Given this list of marker genes SHH, PTEN, RPS6KA3, RAB33B, BICRA, XYLT1, PGAP2, RPS27, NALCN, EIF2AK3, CSGALNACT1, LAMB3, CTSC, RPL27, DYNC2LI1, CWC27, TMEM231, NONO, SKI, TMEM216, GP1BB, CHST11, TGFB2, ADA2, CEP290, JAG1, COL6A3, CTSK, PORCN, KCNN3, MACROH2A1, SALL1, B9D2, ACTG1, DHCR7, TBX3, C2CD3, PROP1, EXTL3, PLOD3, ARID1B, IFT52, SHMT2, OTUD6B, SUZ12, DYNC2H1, COL5A1, INTU, KCNK9, ASAH1, MIR17HG, FGFR3, MIR140, EDA, COL11A2, DNA2, ZNF668 (NCBI Gene Id 79759), ADAMTS15, FTSJ1, FANCC, TNNI2, GABRD, NIN, PTDSS1, TMEM138 (transmembrane protein 138), PIBF1, DEAF1, CHD7 (chromodomain helicase DNA binding protein 7), ZIC3, NUP88, LMBR1 (NCBI Gene Id 85501), TCTN1, UBAP2L, RBPJ, LAGE3, SMOC1, PQBP1, GATA1, SLC29A3, EVC, COL6A2, DOCK6, GPC4, MEIS2, GNAS, PIK3CA, ERCC6, TMEM107, KATNIP, PRKCZ, KMT2A, COL10A1, SMARCA2, MUSK, FLII, WNK1, FGFRL1, RPL8, BMPR1B, IFT122, IDS, BRF1, MAN2C1, CFAP418, COG4, RPS24, MYBPC1, KIF15, RLIM, SPEN, RPS28, MYH8, FANCE, PIEZO2, LONP1, SMARCB1, AKT3, RTL1, ATP6V1B2, MBD5, RMRP, NOD2, SOST, TRPS1, ACTB (NCBI Gene Id 60), TSR2, TGFBR2, GJA5, NSUN2, LIG4, WFS1, MTOR, SMC1A, GDF5, BMPR1A, HPGD, FGF10, PHF8, ARPC4, DYNLT2B, FANCA, LMNA, RPL11, ANAPC1, NOG, ERCC8, MBTPS2, FBXO11, TMEM218, PUF60, IFIH1, LHX4, PAX3, MORC2, ROR2, PRKACA, NLRP3, RPL31, AMMECR1, WDR4, HIRA, FRAS1, H3-3B, ARID1A, FLI1, PHF6, SMO (NCBI Gene Id 6608), EBP, DDX59, RAB23, COMT, MAP3K7 (mitogen-activated protein kinase kinase kinase 7), KIAA0825, DHX30 (NCBI Gene Id 22907), MEGF8, SCLT1, NGLY1, IGHMBP2, EXOSC2, CEP120, DLL4, TCTN3, ACAN, IPO8, RUNX2 (RUNX family transcription factor 2), TAF6, CD96, CANT1, GNPNAT1, EVC2, HSPG2, PRDM16, TOGARAM1, LHX3, RAB3GAP2, TDO2, FAM149B1, FLNA, IFT57, RPL10, TPRKB, BRD4, TRIP11, B4GALT7 (beta-1,4-galactosyltransferase 7), EZH2, TRPV4, MTX2, CEP19 (NCBI Gene Id 84984), CDKL5, WDR35, IGF2, HOXA13, BBS12, RPL35A, TNNT3, RPGRIP1L, CC2D2A, HOXD13, POR, POC1A, TRAPPC2, CDC6, NFKBIL1, TGFB3, NEPRO, ROBO1, ACTG2, PDGFRB, TFAP2A, PIGS, JMJD1C, CNOT1, NELFA, WDPCP, WNT7A, FANCI, CEP41 (centrosomal protein 41), FLNB, UNC80, TMEM70, ARVCF, PEX1, IDH1, ADAMTS3, POGZ, BBS7, SRCAP, RIGI, BCOR (BCL6 corepressor), H3-3A, SMAD3, PIK3CD, PTHLH, ZDHHC9, RREB1, DVL1, GLI2, OCRL, ERCC2, BMP4, KIF1A, COG5, FGFR1, ORC1, PIGG, MMP2, STAMBP, RAB34, CBY1, PIGN, MGP, CEP104, NEK1, MAP3K20, PIGV, GATAD2B, USP9X, CIBAR1 (CBY1 interacting BAR domain containing 1), TFAP2B, ADAT3, G6PC3, PRKAR1A, IL11RA (interleukin 11 receptor subunit alpha), TBX1, CCDC22, PRG4, PUM1, KIF7, RECQL4, KMT2D, CBFB, RTTN, GMNN, SLC39A13, TRIO (trio Rho guanine nucleotide exchange factor), SETD5, PSMB8, ADAMTS10, LEMD3, DHODH, TPM2, PTPN22 (NCBI Gene Id 5779), LAMA5, SCARF2, MED12, TMEM237, RPL18, PCDHGC4, KIAA0586, IFT27 (intraflagellar transport 27), KCTD1, ZBTB20, MMP23B, TCTN2, EIF4A3, ASXL3, SMARCE1, FGF9, ADAMTS2, RNU4ATAC, SF3B2, TAF4 (TATA-box binding protein associated factor 4), IARS1, CHUK (component of inhibitor of nuclear factor kappa B kinase complex), HEATR3, FGD1, PIGB, RPS17, ERCC1, KCNAB2, DYNC2I1, APC2, GPX4, SH2B1 (NCBI Gene Id 25970), GJA8, H4C9, HINT1, NSD2, MEGF10, CFTR, CREBBP, L1CAM, SLC18A3, TBX2, PCGF2, GDAP1, PPP2R3C, PTH1R, BBS5, SMARCA4, ORC4, CHRNG, IFT74, FERMT1, AEBP1, SMG9, NPR3, CRLF1, PEX6, COL12A1, TXNDC15, GNB2, MYOD1, IL10, BGN, KIF21A, HYLS1, SCN9A, POLR3A, NHS, SF3B4, LFNG, CDC45, ERF, CSPP1, TMEM67, NAA10, GATA4 (NCBI Gene Id 2626), UPF3B, CHN1, TGFBR1, COL11A1, FTO, PRKACB, PGAP3, EP300, CAPN3, ARL6, PCYT1A, SATB2, MAFB, NOTCH2, SMC3, PAH, ARL13B, NSDHL, CTBP1, EOGT, IFT56, ACP5, PCNT, PDE6D, BBS1, WNT5A, TP53RK (NCBI Gene Id 112858), ERCC5, SLC35A3, RPS7, DOK7, WDR73, COL1A1, NUP133, IHH, B9D1, WDR19, DYNC2I2 (dynein 2 intermediate chain 2), MRPS28, MIA3, SLC25A24, MED25, PIGY, MYCN, FBXO28, B3GAT3, ADAMTSL2, MKS1, PNPLA6, NR4A2, VPS35L, XRCC2, PRKD1 (NCBI Gene Id 5587), COL2A1, PDE3A, INPPL1, RPS19, SCNM1, EED, ORC6, UBE4B, BBIP1, CEP152, ATR, SNIP1, SLC22A4, RBBP8, POLA1, HESX1, IQSEC2, ALX4, COMP, EXT1, UFD1, GNPTAB, ASPN, RPS10, ATL3, BBS2, PRKG2, IFT140, PACS1, VAC14 (VAC14 component of PIKFYVE complex), PITX1, EMG1, KAT6B, UBE2T, FBN2, DNMT3A, EFTUD2, GON7, NXN, SC5D, SOX11, ALG6, RBM8A, FANCB, GLI1, TWIST2, MECOM, GGCX, LBR, GLI3, FAT4, BLM, PIGO, CDT1, BMP2, ZMPSTE24, TOR1AIP1, RPL26, RPL5, KCNJ8, TUBB3, TLK2, ALX3, NFIX, RPS26, POLR3GL, MESP2, ANTXR2, CD244, MKKS, CHSY1, PSMD12, RETREG1, NSD1, DPYS, YRDC, SUFU, PIK3R2, TOPORS, SLC26A2, BBS10, KAT6A, IKBKG, SCN4A, RPS20, ZNF407, GJA1, TWIST1, DLL3, BHLHA9, SETBP1, IDUA (NCBI Gene Id 3425), WASHC5, SH3PXD2B, FGFR2, NPR2, POU1F1, RPS29, CDH11, RPGRIP1, ZNF699, KDM5B, COL5A2, LIFR, SDCCAG8, GPKOW, OSGEP, TP63, KIAA0753, KCNJ2, RPL35, HHAT, CRKL, WLS, RPS15A (ribosomal protein S15a), INPP5E, CASZ1, TTC8, FIG4, MAPK1, TBC1D24, IQCE, CUL4B, MYH3, RAPSN, CLCF1, PDE4D, ABCC9, COL3A1, FBN1, CRIPT, HEPACAM, HDAC4, RPL15, PIGW, ZSWIM6 (NCBI Gene Id 57688), ERI1, B3GALT6, CCBE1, OTUD5, CIITA, TMCO1, DSP, NUP107, IFT43, PTCH1, CCDC28B, SOX9, SALL4, ACVR1, CPLX1, ESCO2, TRPM3, ARSL, DLK1, PRMT7, ZNF423, RPL9, IFT80, SMARCAD1, CPLANE1, LRP4 (LDL receptor related protein 4), RAB3GAP1, LUZP1, KDM5C, ARHGAP31, KNSTRN, GPC3, KCNH1, MATN3, BBS9, DDR2, SCAPER, DNM1L, SUMF1, MSX2, ZNF141, TUBA1A, SPTBN1, NPHP1, DYM, DPYSL5, RIPK4, ASCC3, FZD2, HS2ST1 (heparan sulfate 2-O-sulfotransferase 1), BPTF, LETM1, MCTP2, TGDS, ARMC9, HNRNPR, SEC24C, PYCR2, FKTN, TBR1, NOTCH1, AHI1, HES7, HDAC8, MAGEL2, COL6A1, MAX, CCN6, TBX5, ABCA12, DACT1, ACTL6B, EDA2R, ADNP, PIGL, PIGF, TONSL (tonsoku like, DNA repair protein), CLCN7, CCND2, BANF1, SIAH1, KRT14, KDM6A, RIPPLY2, ARL3, PLAA, PDPN, TBC1D2B, OFD1 (OFD1 centriole and centriolar satellite protein), CHST3, FN1, NEDD4L, FANCD2 (FA complementation group D2), KIF22, EFNB1, ALX1, BBS4, TRIM32, MEG3, MYL11, ACOX1, TTC21B, LZTFL1, RERE, IFT172, NIPBL, RAD21, SMAD2, DVL3, RBM10, BCR, SLC35A2, RAI1, here is a description of the gene set: studied in species Homo sapiens Human Gene Set: HP_ABNORMAL_FINGER_PHALANX_MORPHOLOGY Abnormalities affecting the phalanx of finger. Abnormal finger phalanx morphology